The following is a description of a gene set: Abnormal nasolacrimal system morphology An abnormality of the nasolacrimal drainage system, which serves as a conduit for tear flow from the external eye to the nasal cavity. Human Gene Set: HP_ABNORMAL_NASOLACRIMAL_SYSTEM_MORPHOLOGY studied in species Homo sapiens, and this is the list of marker genes: EYA1, SLC25A24, KAT6B, GJB6, PEX6, SIX1, MBTPS2, PIK3CD, BIRC3, KMT2D, TAF1, EP300, FOXL2, NIPBL, HLA-DPB1, BTNL2 (NCBI Gene Id 56244), GJB2, SF3B4, SMC5, CD151, PPP2R3C, UBR1, KDM6A, BCL10, FGFR3, COX7B, KIF11, FGFR1, PPP1CB, MED12, POLR1D, LEMD3, PEX1, GLI2, SIX5, FRAS1, TCOF1, SMCHD1, TFAP2A, KRAS, CTLA4, SATB2, MEGF8, IGSF3, SOX10, CREBBP, FGF10, PTDSS1, HLA-DPA1, FREM1, YY1, KAT6A, KNSTRN, TET3, SOX6, PAX3, HLA-DRB1, PTPN22 (protein tyrosine phosphatase non-receptor type 22), COL3A1, NOP10, PRMT7 (NCBI Gene Id 54496), POLR1C, PRTN3, GRIP1, USB1, TWIST1, TGDS, TRRAP, FREM2, NDUFB11, FGFR2, MALT1, FOXP1, SMC3, PRR12, POLR1B, HMX1, SPRED2 (sprouty related EVH1 domain containing 2), PAX1, HCCS, TP63, NHP2